The following is a description of a gene set: species: Mus musculus SUMOylation Mouse Gene Set: REACTOME_SUMOYLATION, and this is the list of marker genes: Nup58, H4c1, Suz12, Ddx17, Hic1, Dnmt1, Parp1, Pias4, Pml, Tpr, Top2b, Ncoa1, Nup107, Uba2, Ppara, Nr1h3, Hdac1, Ar, Nr5a1, Nup210, Phc2, Sae1, Nup50, Safb, Sec13, Smc5, Nsmce2, Sumo3, Nr3c2, Npm1, Hipk2, Uhrf2, Nup54, Bmi1, Stag1, Aurkb, Daxx, Rangap1, H4c4, Nup160, Rwdd2b (RWD domain containing 2B), Nr1h4, Incenp, Nup88, H4c11, Nr1h2, H4c6, Ctbp1, Trim27, Pom121, Pias2, Ndc1, Nup62, Nr5a2, Rara, Pgr, Nup35, Nsmce1, H4c9, H4c17, Satb2, Thra, Ing2, Nsmce3, Xrcc4, Nup37, Rad52 (NCBI Gene Id 19365), Nup42, Sumo2, Tdg, Ranbp2, H4c18, Pias3, Nup205, Topors (NCBI Gene Id 230074), Rora, Vhl, Eid3, Sumo1, Ring1, Esr1, Cbx2, Senp2, Sp100, Nup214, Nup93, Mbd1, Brca1, H4c14, Nup153, Smc3, H4c8, Nr3c1, Rela, Hnrnpc, Herc2, Cbx8, Cetn2, Hdac7, Rae1, Phc1, Nup98 (NCBI Gene Id 330609), Nup43, Top1, Hdac4, Pcgf2, Mdm2, Blm, Pcna, Nop58, Vdr, Cdca8, Rnf168, Nfkbia, Smc1a, H4c3 (NCBI Gene Id 319155), Sin3a, Nr1i2, Mrtfa, Nup188, Nup155, Dnmt3b, Rxra, Top2a, Mdc1, Rpa1, Mta1, Phc3, L3mbtl2 (L3MBTL2 polycomb repressive complex 1 subunit), H4c2, Senp1, Nup133, Casp8ap2, Stag2, Hnrnpk, Trp53bp1, Senp5, Ube2i, Zfp131, Smc6, Aaas, Satb1, Foxl2, Pias1, Nfkb2, Scmh1, Tfap2c, Rad21, Seh1l, Sp3, Ikbke, Nsmce4a, Cbx4, Nup85, Ddx5, H4c16, Rnf2, Park7, Thrb, Nrip1, H4c12, Xpc, Ikbkg, Ep300, Mitf